The following is a description of a gene set: Any process that stops, prevents, or reduces the frequency, rate or extent of JUN kinase activity. Mouse Gene Set: GOBP_NEGATIVE_REGULATION_OF_JUN_KINASE_ACTIVITY studied in species Mus musculus, and this is the list of marker genes: Gstp3, Gstp2, Nppa, Ptpn22, Gstp-ps, Dusp19, Sfrp2, Dnaja1, Sfrp5, Hipk3, Sfrp1, Pdcd4, Mapk8ip1, Aida, Dusp10, Gstp1